Given this list of marker genes NDUFB11 (NCBI Gene Id 54539), CITED2, HCCS, COX7B, MT-CYB, TTN, here is a description of the gene set: AV nodal tachycardia Human Gene Set: HP_AV_NODAL_TACHYCARDIA A type of supraventricular tachycardia that originates in the atrioventricular node. studied in species Homo sapiens